Given this list of marker genes Gas8, Mir7076, Gm26994, Mir7077, Crispld2, Spire2, 1190005I06Rik, Gm45857, Gm38416, Wfdc1, Gm42047, 4732419C18Rik, Chst5, 9430091E24Rik, Rps12-ps9, Gm26132, n-R5s103, Gcsh, Gm22193, n-R5s100, 5033426O07Rik, Gm26878, Acsf3, Gm20735, Znrf1 (zinc and ring finger 1), n-R5s130, Cbfa2t3, 4933408N05Rik, Gm32352, Dpep1, Gm17786, Gm31774, Ddx19a, Gm4316, Cdh15, Hsbp1, Jph3, Spata2l, Hsdl1, Gm16118, n-R5s106, Mir7078, Gm30052, 6430548M08Rik, Rnf166, Tcf25, Slc38a8, Mtss2, Afg3l1, Gm15894, Pdpr, Cntnap4, Fbxo31, Gm5357, Map1lc3b, 1700016A09Rik, A130014A01Rik, Klhl36, Spg7, Il34, Mir7687, Mlycd, Cfdp1, Sdr42e1, Vat1l, Ddx19b, Cdh13, Clec3a, n-R5s143, Zdhhc7, Vps9d1, Zfp276, Mvd, Mbtps1, Gm25200 (predicted gene, 25200), Gm16378, 2810013P06Rik, Gm15395, n-R5s111, Gm22827, Ctu2, Terf2ip, Fa2h, 1700030J22Rik, Mphosph6, Gm26739, Gm39271, Taf1c (TATA-box binding protein associated factor, RNA polymerase I, C), Rps13-ps4, n-R5s122, Fendrr, Snord111, Klhdc4, n-R5s110, 4930422C21Rik, Rpl13, Irf8, Gm27011, Syce1l, A530010L16Rik, Ankrd11, Mon1b, 1700030M09Rik, Maf, Il17c, Mlkl, Gm24793, Gm25766, Gan, Bco1, Cdt1, Gm6793, Pkd1l2, BC048644, Zfp1 (NCBI Gene Id 22640), Clec18a, Fanca, Cyba, C230057M02Rik, Hsd17b2, Aprt, Gins2, Gm27021, Aars1, Car5a, Zc3h18, Rfwd3, Atp2c2 (ATPase, Ca++ transporting, type 2C, member 2), Necab2, n-R5s129, A330074K22Rik, Slc7a5, Mir7080, Piezo1, Gm10614, Snord68, Foxf1, Ldhd, 1700018B08Rik, Meak7, Adat1, Cpne7, Cibar2, Gm18709, Gm45904, n-R5s125, Chmp1a, Def8, n-R5s102, Osgin1, Gm15895, Cmip, 1700018P08Rik, Mir7079, Sult5a1, Cenpn, Foxc2, Zfp469, Cmc2, Adamts18, Gse1, Cog4, n-R5s105, n-R5s104, 4933417D19Rik (NCBI Gene Id 71186), Gm31717, Mc1r, Tubb3, Mthfsd, Rn5s, Zcchc14, Gm16117, Gabarapl2, Mir7237, Gm16116, Cdyl2, n-R5s117, Trhr2, Gm45723, Tmem170, Galns, Banp, Gm10280, Adad2, Cox4i1, Dnaaf1 (NCBI Gene Id 68270), Zfpm1, Pabpn1l, Atmin, 6030466F02Rik, Cdk10, Dynlrb2, Spata33, Gm22291, Trappc2l, Rhou, Dbndd1, Snai3, Wdr59, Gm33142, Gm10612, Exosc6, 9530085P06Rik, Glg1, Ctrb1, Usp10, Nudt7, Tmem231, Gm24291, Cotl1, Gm3635, Gm26812, Wwox, Fcsk, Plcg2, Foxl1, Gm22999, Sf3b3, Emc8, Kars1, Kcng4, Bcar1, Gm26497, Gm17709, Gm23677, n-R5s127, St3gal2, n-R5s115, 4930488N15Rik, Gm26747, Mir6396, Gm38523, Mir3473d, here is a description of the gene set: studied in species Mus musculus Mouse Gene Set: chr8E1